Given this list of marker genes Mmp28, Runx3, Usp25, Siah2, Peli2, Nipal1, Akap13, Optc, Zfp704, Msrb3, Tsn, Trim56, Fbxo30, Hoxb4 (homeobox B4), Tet2, Cacna2d4, Prlr, Grid1, Grik3, Creb3l1, Trpc5, Pcmtd1, Peg3, Vangl2, Dock5, Nt5e, Kcnip3, Fam169b, Katnal1, Six6, Kif1a, Zeb2, Acvr2b, Adgra1, Bptf, Maf, Xk, Galnt13, Cxcl15, Pld5, Tlx1, Tmem104, Cntn2, Tvp23a, Arhgap25 (NCBI Gene Id 232201), Pcdhga10, Bmpr2, Rusf1, Fbxo31, Rpp25, Tmod2 (tropomodulin 2), Ttc12, Rhobtb1, Ubtf, Lrtm2, Adhfe1, Fgfrl1, Setd3, Btbd3, Asah2, Cacna1c, Diaph2, Sowaha, Ms4a5, Brwd3, Nudt13, Rora, Gabrg2, Hoxc13, Nkain2 (NCBI Gene Id 76197), Ptpn14 (protein tyrosine phosphatase, non-receptor type 14), Nkain3, Knstrn, Cox16, Cfap74, Spock2 (sparc/osteonectin, cwcv and kazal-like domains proteoglycan 2), Polr3b, Acvr2a, Rp1, Napepld, Acmsd (amino carboxymuconate semialdehyde decarboxylase), Pcdhga9 (NCBI Gene Id 93717), Lbp, Dnaaf5, Pou3f4, Prkca, Acp1, Gab2, Cd47, Hif1an (hypoxia-inducible factor 1, alpha subunit inhibitor), Cdh6, Ssr1, Itga3, Cyfip1, Vapb, Snap23, Gnaz, Homer2, Zfp91, Gm14434, Zfp74, Xylb, Ipcef1, Ly6g6c, Chst2, Bltp3b, Ggt5, Rhbdd1, 3425401B19Rik, Elavl3, Kcnj1, Aldh5a1, Actr10, Maml3, Rassf2, Fech, Cyp2g1 (NCBI Gene Id 13108), Astn1, Aldh8a1, Borcs8, Bach2, Gcnt1, Mon1b, Zfp831, Ppih, Cnpy3, P4ha3, Jmy, Ehd4, Mtmr12, Rgs9bp, Krt6b, Adamts17, Hexim2, Unc5d, Snurf, Supt7l, Clec2l, Mbtd1, Garre1, Sin3a, Pdzrn3, Ece1, Pcdhgb4 (protocadherin gamma subfamily B, 4), Unc5c, Lclat1, Tmem52b, Pfn1, Srpx2, Mapk11, Mnt, Tor3a, Clec4g, Slc35a3, St8sia3, Fgf23, Tcte1, Tgfa, Prkci, Atp11a, Gpr68, Wnt4, Abcc9, Sp9, Igfbp3, Plppr3, Prss23, Klhl9, Scd3, Zfp606 (NCBI Gene Id 67370), Macroh2a2, Draxin, Rab9, Arid1b, Pou6f1, Foxa1, Slc8a1, Igsf6, Pate9, Kras, Rasal2, Avl9, Ceacam2, Trpc6, Meltf, Phf1, Ado, Itga4, Rnf44, Tmem236, Gfod1, Gabrb3, Pdcd4, Tti1, Gm14325, Trip12, Cbln3, Dcaf17, Zfp764, Camk1d, Pcdhgb8, Elovl6, Tmem132b, Prkcg, Cgas, Ceacam18, Wrn, Serinc3, Pcdhgb6, P2rx7, Septin6, Mtus2, Prelid3a, Wscd1, Vtcn1, Rnf150, 1700028K03Rik, Mmab, Stk32a, Hrh1, Efna5, Opcml, Trp53i11, Chrdl1, Magee2, Gabrb2, Tmem141, Gm3604, Cdc6, Sytl5, Dse, Cacna2d2, Gnal, Pde1c, Wipf3, Zfp1008, Treml2 (NCBI Gene Id 328833), Svip, Gabbr1, Loxl4 (lysyl oxidase-like 4), Sh3rf3, Cyb5b, Trub2, Bnc2, Bmp3, Rpusd2, Vsig10l (V-set and immunoglobulin domain containing 10 like), Tpgs2, Krt222, Prss42, Prim2, Slc8a3, Lnpk, Kcnmb1, Pank1, Zfp663, Ccna2, Tenm2, Zdhhc21, 1700025G04Rik, Cds2, Nqo2, Fig4, Ccdc71l, Dhh, Glra1, Kat6a, Foxl1, Trim12c, Megf8, Ube2q1, P2ry13, Cxcl12, Adra1b, Prdm12, Gm38666, Atp2b3, Smpd4, Sys1, Ppp1r1c, Vti1a, Tnrc6c, Fam107a, Srf, Ptgdr, Apbb2, 4921509C19Rik, Kcnq2, Nbeal1, Pilra, Nat8l, Srxn1, Oprm1, Shroom3, Nfya, Bicd1, Cdc27, Prxl2a, Gcm2, Enpp1, Slc6a17, Kirrel3, Baiap2, Cnksr2, Ilrun, Ulk1 (NCBI Gene Id 22241), Mapk8, Arhgdib (NCBI Gene Id 11857), Acox3, Dmrta1, Ackr4, Cask, Kif3a, Itgam (integrin alpha M), Ddx19b, Shisal1, Foxk1, Ajap1, Nid1, Pgrmc1, 2810021J22Rik, Pcdhga8, Cd300ld, Spx (NCBI Gene Id 319552), Prox1, Slc31a2, Bard1, Nagpa, Gnat1, Doc2b, Baz2b (bromodomain adjacent to zinc finger domain, 2B), Plxdc2, Pcdhgc3, Slc22a8, 9030624G23Rik, Dlgap2, Ttc4, Trpm3, Thsd4, Chd7, Slc7a1, Nrk, Sox12, Cd19 (NCBI Gene Id 12478), Cd33, Rabgef1, Med14, Vps37a, Smyd3, Fndc3a, Papss2, Marchf1, Cyp2j12, Pirt, Rgr, Cacna1e, Frk, Pcdhgb5, Scn2a, Zc3h12d, Scaf11, Unc13b, Nfasc, Pitpnb, B4galnt2, Tmem178b, Zfp449, Creg1, Zfp747, Barhl2, Csf2ra (colony stimulating factor 2 receptor, alpha, low-affinity (granulocyte-macrophage)), Col13a1 (collagen, type XIII, alpha 1), Prkcb, Ostm1, Rad18, Ttll1, Cd4, Nedd4l, Ewsr1 (Ewing sarcoma breakpoint region 1), Calcoco1, Tead1, Fblim1, Dhfr, Scn8a (sodium channel, voltage-gated, type VIII, alpha), Pcdhga3, Arhgap26, Mafb, Tph1, Kcng3, Dnah17, Fbxl17, Sh2b3, Eif4e, Osr1 (NCBI Gene Id 23967), Sspn (NCBI Gene Id 16651), Mlxip, Slc6a6, Lgals12, Cpm, Kcna2, Mobp, Hdac8, Gm14391, Nxpe3, Pogk, Sema6a, Lin7a, Tmem26, Pik3r5, Coro2b, Nck2, Ddo, Tfap2b, Klhl23, Man2a2, Foxn1, Zscan29, Acsl4, Mmp12, Ubxn2a (UBX domain protein 2A), Cstad, Ptprb, Zfp810, Mta3, Nkap, Zfp712, Zfhx3, L1cam, Pcdhga11, Ski, Rfk, Col19a1, Depdc5, Ddx51, C1ql3, Cdh7, Alkbh7, Chst11, Vipr2, Sv2a, Bcor, Napb, Chmp1b2, Gcnt4, Ttc39b, Ctdsp2, Myorg, Kcnc1, Gata4, Gask1a, Gucy2e, Prr5l, Hnrnpa0, Runx1t1, Neurod2, Naip6 (NLR family, apoptosis inhibitory protein 6), Zfand5, Cyb5r3, Enpp6, S2bpcox16, Septin11, Sox5, Cradd, Galntl6, Zfp39, Kank2, Smo, Fgf11, Casp6, Pcdhga12, Nr4a2, Flrt1, Pcdhgb7, Zfp318, Fzd3, Slc37a1, Iars1, Ascl4, Rab11fip4, Atg7, Snai2, Cd84, Mylk4, Cd28, Asap3, Evx2, Evi2b, Cox15, Rnf170, Esf1, Cnot7, Zfp488, Micu2, Gng12, Frmd5, Stxbp5, Tcp11l1, Pde10a, Slc25a31, Ildr2, Hook3, Nhsl1, Pgm5, Pou2f2 (POU domain, class 2, transcription factor 2), Nkx2-9 (NK2 homeobox 9), Dlg1, Urod, Elavl4, Ctse, Kdm6b, Gm14151, Rras2, Cox10, Ccbe1, Gng2, Asxl2, Nav1, Deup1, Rab2b, Lhfpl3, Usp45, Rnft1, Chic1, Cnih3, Ufm1, Tppp, Kcnn3, Xrcc3, Coq8a, Baalc, Snrpn, Runx1, Nwd1, Slc35d2, Vps33a, Klhl13, Rims2, Mgat4a, Hmga2, Ncam1, Heatr6, Lpp, Flnb, Has2, Actr1b, Cd274, Man1c1, AW554918, Camk2a, Zfand2a, Pcdhga2, Sdr42e1, Wiz, Nrp2, Prrc2b, Epha7, Slco2a1 (solute carrier organic anion transporter family, member 2a1), Spin1, Lsm1, Ppp1r9a, Fbrs, Golm2, Nsun3, Sh2d2a, Net1, Eef2k, Zfp976, Rit2, Pcdhgc4, Ano3, Dcun1d1 (NCBI Gene Id 114893), Ttc14, Slc38a6, Tafa1, St8sia1 (NCBI Gene Id 320852), Zyg11b, Trim60, Adarb2, Gm2026, Rgs17, Rab3c, Arpp21, Fgf12, H2bc6, Dio2, Gjc3, Prkaa1, Ceacam1, Zfp655, Kcnb1, Acp3, Csmd1, Map3k20, Gm4724, Cd99l2, Rabl2, Cd2ap, Dhx40 (DEAH-box helicase 40), Zmat4, Cmah, Iqgap2, Vsnl1, Hivep3, Cdk5r1, Rgs5, Ermap, Elp4, Mrpl19, Nmnat2, Ift57, Gbp7, Nmrk1, Tmem18, Porcn, Rnpc3, Psd2, Gm14308, Gas2l3, Sike1 (NCBI Gene Id 99724), Dcdc2a, Tgfbrap1, Smarca2 (NCBI Gene Id 67155), Bcl2l11, Gm12886, 2510009E07Rik, Rslcan18, Iglon5, Srp9, Dppa1 (developmental pluripotency associated 1), Mrpl17, Cdk6, Ugt2b34, Mfsd6, Mcu, Lrat, Lcorl, Cldn34c1, Mllt3, Chst3, Arhgef9, Map3k7, Prps1l1, Uvssa (NCBI Gene Id 71101), Ppfia2, Srsf12, Zfp827, Sbk3, Garem2, Methig1, F830016B08Rik (RIKEN cDNA F830016B08 gene), Esr2, Gadl1, Egfl6 (EGF-like-domain, multiple 6), Gulp1, Il1rap, Cipc, D630003M21Rik, Zmiz1, Rrm2, Pigh, Trim36, Stk10 (serine/threonine kinase 10), Slc39a14, Pcdh10, Vamp5, Rorb (NCBI Gene Id 225998), Elfn1, Cyth3, Phactr3, Neu1, Gpr45, Fzd7, Kmt5a (lysine methyltransferase 5A), Zfp37, Cdh20, Sv2b (NCBI Gene Id 64176), Slc10a2, Plp1, BC030500, Tigd5, Slamf1, Zbtb7b, Rspo1, Slc17a5, Elfn2, Psg29, Alg12, Cdc42ep4, Tacc1, Nab2, Zfp248, Rab7, Lrrn4cl, Rgs4, Ptchd1, Hycc2, Fat3, Dtx3l, Arhgef17, Sod2, Igf2, Ap3s2, Ric8b, Tnpo3, Elovl5, Dctd, Klf12, Mrap, Pck2, Metrnl, Chic2, Chrnb4, St18, Glra2, Abce1, Rfx7, Paics, Tnfrsf13c, Havcr2, Fam171a1, Apba1, Nalf1, Arih1, Ccdc85a, Lrrc32, Pacsin2, Zfp266 (zinc finger protein 266), Zfp696 (zinc finger protein 696), Zrsr2, Flt4 (FMS-like tyrosine kinase 4), Stxbp4 (NCBI Gene Id 320264), Dnase1l3, Sh3bgrl2, Npr3, Sema5a, Rimkla, Atm, Adcy1, Orai2, Thada, Kcnj15, Map7d1, Syt15, Epha4, Mocs1, Ctsc, Dph6, Endov, Slc1a2, Tbx15, Htra4, Snx12, Alox8, Unc93a, Mettl27, Ggact, Slc4a4, Glyr1, Stat6, Erg, Cd27, Setd7 (SET domain containing (lysine methyltransferase) 7), Tmem151b, Ehd3, B3gnt9 (NCBI Gene Id 97440), Oacyl, Sh3bp5, Pou3f2, Tmco1, Otx1, Igf1r, Mettl21e (methyltransferase like 21E), Irag1, Ifi44, Pcdh8 (NCBI Gene Id 73497), Edaradd, Cplx2, Sdf4, Pcdhga4, Atg10, Trem1, Ubfd1, Tgfb2, Csrnp2, Slc2a12, Ap1ar, Rfx3, Bdh1, Tmt1a3, Dusp7, Ngfr, Senp1, Prdm8, Meis2, Prss59, Slc7a8, Atp7a, Ino80d, Scn3b, Zfp239, Vwa5b2, 9330159F19Rik, Mrgpre, Slc4a8, Il22ra1, Dmd, Pakap, Cerk, Grk3, AI429214, Brix1 (NCBI Gene Id 97948), Ncoa2, Rmi1, Srgap3, Cplx3, Cntn3, Cmc2, Fam149b, Steap2, Trpc7, Cstf3, Tamalin, Iffo2, Zfp612, Lhx5, Mdm2, Myo5a, Sox7, Dlgap4, Gls, Irf2bp2, Zfp575, Micall1, Septin3, Lnx2, Myrip, 1110059E24Rik, Wars2, Plpbp, Kcnv2, Fubp1, Nfat5, Ccdc115, Tmem200a, Tc2n, Yipf6, Tmem150c, Zfp276, Adtrp, Tacr1, E2f8, Sowahb, Vegfb, Anks1b (NCBI Gene Id 77531), Oxsm, Peak1, Mapkbp1, Cdk13, Atxn1, Ttc38, Cdc37l1, Creg2, Unc5a, Mcidas, Gna13, Adgrf5, Dcaf1, Prpf4, Nufip1, Pcdhgb1, Brinp1, Zfp516, Gas2l1, Tafa3, Pgbd1, Slmap, Ddr1, Fndc7, Accs, Prkn, Enox2, Tubb4a, D630045J12Rik, Pcdhga5, Xpr1, Glis3, Pign, Ank2, Pecam1, Pura, Zfp365, Mblac2, Zkscan1, Mical2, Thsd7a, Angpt2, Rnft2, Bean1, Synj2bp, Dcakd, Slc35e2, Dkk1, Ift46, Plac9, Btbd8, Htt, Tcaim, Pfkfb2, D630023F18Rik, Ifnlr1, Bcl2, Dixdc1, Rnasel, Cd160, Jmjd8, Prdm6, Zfp113, D430019H16Rik, Glce, Zfp446, H2-M2, Idua, Pcdhga6, Tirap, Zfp607b, Riok3, Wdr59, Eda2r, Fam174b, Acss1, Slc30a10, Triobp, Pitpnc1, Extl3, Klf6 (NCBI Gene Id 97911), Pcdhga7, Mecp2, Cfap97, Pard3b, Reps2, Art1, Pcdh17, Mga, Slco3a1, 1810065E05Rik, Irgm2, Apela, Prex2, Eogt, Ago3, Proser3 (NCBI Gene Id 333193), Pcdhgb2, Slc22a15, Rhou, Muc4, Katnip, Psd3, Ubxn2b, Cp, Nphp3, Mymk, Cnga4, Lyrm9, Sipa1l1, Atp2b2, Wipf2, Cap2, Ppp1r16b, Coq5, Fsd1l, Oxtr, D630039A03Rik, Rasa2, Alpl, Pgap1, Nab1, Nrbp2, Dapp1, Ptch2, Pof1b, Ncam2, Nrxn1, Fermt1, Gm6710, Lrrc61, Desi2, Ms4a4c, Slc48a1, Gatc, Zfp799, Aptx, Plcb1, Gm4925, Tmtc3, Plxna2, Chn1, Onecut2, Igf2r, Chrnd, Zfp46, Clvs1, Urb2, Zfp68, Maea, Bst1, Mex3a, Zfp329, Pnma2, Cer1, Ogdh, Prr11, Olig2, Stambp, Nmrk2, Mlec, Ssbp4, Dcx, Clptm1, Stard8, Dgkg, Pafah1b1, Itga11, Trim67, Lhx6, Tent5a, Pstpip2, Ugcg, Mbnl3, Sarm1, Cygb, Syn3, Cgnl1, Mbtps2, Gm14137, Fbxw5 (F-box and WD-40 domain protein 5), Nat8f2, Iars2, Acot3, Hpca, Prr18 (NCBI Gene Id 320111), Mrps25, Kmt5b, Pclo, Atrn (NCBI Gene Id 99420), Prokr2, Vezt, Pappa2, Sparc, Kcnk10, Lims1, Shisa6, Trim65, Greb1, Pou4f2, Scn5a, Prc1, Deptor, Carm1, Lipe, Slc24a2, B3galt1, Rab6b, Gdpgp1, Ralgapa2, Il18r1, Eif2b3, Podn, Cat, Tmem47, Ebf3, C5ar2, Bend3 (NCBI Gene Id 331623), Mfap3l, Mr1, Emx2, Ddi2, Nrip3, Ints10, Nos1, Acsm2, Tbc1d30, Lcmt2, Itga9, Pcdhgc5, Dlg4, Ankrd34a, Rreb1, Ascl1, Wdr46, Gid8, F10 (coagulation factor X), Slc25a10, Tyw3, Gtf2h2, Tub, Nufip2, Slc16a5, Ubap2l, Sp100, Slc5a8, Asb13, Acot4, B4galt5, Fbxw28, Dhdh, Fcrl6, Zfp92, Cend1, Dnlz, Rbm34, Terf2ip, Pdik1l (PDLIM1 interacting kinase 1 like), Lratd1, Efcab14, Dnai4, Aak1, Slc25a21, Acot2, Pcdha4b (NCBI Gene Id 100384868), Gfpt1, Amotl1, Pdxk, Znrf3, Camta1 (calmodulin binding transcription activator 1), Tns1, Kcna7, Samd7, Ccdc125, Lyz3, Sim1, Ptpre, B4galt6, Zfp169, Pcdhga1, Tnr, B3galt6, Adam12, Tnfrsf11a, Insyn2a, Capn6, Celf4, Rara, Pfkp, Casp8, Sox1, Gabrq, Ptgfr, Mindy2, Lcp2, Mdga1, Jarid2, Adamts14, Pappa, Vangl1, Itsn1, Zfp936, Nlgn3, Kif5a, Sptlc2, Uncx, Gm5141, Hspg2, Zfp691, Stxbp5l, Ralb, Insr, Egr3, Fam186b, Ccdc3, Cmklr1, Cflar, Slc6a1, Cyp4a31, Zfp641, Sri, Plekhg5, Trim30d, Zfp994, Meak7, Rab11fip1, Muc13 (NCBI Gene Id 17063), Mapk6, Fmn2, Tacr2, Gria3, Sema5b, Slc25a12, Onecut3, Ttll7, Gabra2, Trmt2b, Bdp1, Igf2bp2, Tktl2, Brinp2, Bgn, Cdh12, Gpr173, Ythdc2, here is a description of the gene set: from publication Chen Y, Wang X (PMID 31504780) species: Mus musculus Mouse Gene Set: MIR_466D_5P Genes predicted to be targets of miRBase v22 microRNA mmu_miR_466d_5p in miRDB v6.0 with MirTarget v4 prediction scores > 80 (high confidence targets).